Given this list of marker genes Gm17968, Gm5533, Bpnt1, Capn2 (calpain 2), Brox, Taf1a, Gm37254, Fam177b, 4930488B22Rik, Mir1981, Tlr5, Gpatch2, Gm33973, 1700007P06Rik, Aida, Hlx, 5033404E19Rik, Mark1, Dusp10, 9630028B13Rik, 2010103J01Rik, Enah, Gm8197, 1700056E22Rik, Gm8214, 2900092O11Rik, 1700112H15Rik, A730004F24Rik, Gm5706, 2700078F05Rik, Gm23690, Capn8 (calpain 8), Gm34068, Gm26169, A430105J06Rik, Fbxo28, Susd4, D1Pas1, Mtarc1 (NCBI Gene Id 66112), Eprs1, Gm3809, Hhipl2, 1700023G09Rik, Vmn1r1 (NCBI Gene Id 632642), Gm34732, Esrrg, Ccdc185, A430073I11Rik, Gm37339, Mia3, Mir215, 4930532G15Rik (NCBI Gene Id 75182), Iars2, Degs1, Rrp15, Rab3gap2, Spata17, Mir194-1 (microRNA 194-1), Gm2061, Gm34882, C130074G19Rik, Lbr, Gm9722, Gm15509, Mir664, Gm10517, Gm19058, Gm37885, Gm23349, Srp9, Disp1, Rpl21-ps1, Lyplal1, Slc30a10, 1700047M11Rik, Tgfb2, 9330162B11Rik, Gm34342, Gm37896, Mtarc2 (mitochondrial amidoxime reducing component 2), Trp53bp2, 4930433J02Rik, BC085271, here is a description of the gene set: species: Mus musculus Mouse Gene Set: chr1H5